Given this list of marker genes EPM2A, CEP57L1, AEBP2, DGKH, ERO1B, ZNF107, SOX17, DESI2, DPY19L4, CD99, C1orf43, ADCY3, KLHL11 (kelch like family member 11), LIMS3, KRBOX4, HSPA12A, RIMKLB (ribosomal modification protein rimK like family member B), KNOP1, RASSF8, PWWP2A, AKAP1, MAP7D2, LRRC19, ZIC3, SEMA3E, PTPRU, RAD51AP1, PUM2 (pumilio RNA binding family member 2), HHIP, CLVS2, TBL1XR1, C1QTNF7, TPP2, COX11, KRTAP4-3, APOBEC4, EML1, LIMS4, DIMT1 (DIM1 rRNA methyltransferase and ribosome maturation factor), GRIN2A, RPL7L1, PIH1D2, PLSCR1, RAPGEF2, COX16, RETREG1, CABS1, PARVA, F2R, SSPN, MCTP2, GALNT13, CD69, MLX, ZDHHC15, UBE2L3, HERC4, PTBP2, PSENEN, SYNJ2BP-COX16, DIS3, IDI1, MAPK10, CCDC25, ATRX, OSER1, GDA, DHX33, MYEF2, TRDMT1, ZFR, ALG13, AOC3, CDYL2, EBF3, ULK2, SLFN12, STAU2, RAB6D, ZBTB20, TFRC, TBL1X, FAM227B, NTS, ENPEP, AASDH, ACO1, C6orf89, TMEM255A, SLC4A10, PIK3C3, LARGE1, ZSCAN20, SGCB, WDR89, VPS13C, MED30, GTDC1, TMSB15B, FANCF, DRP2, ARL5B, LCORL, CD46, IFT80, FCHSD2, ZNF678, PGGT1B, FAM199X, ILRUN, EDIL3, RAB3C, CLEC7A, TMSB15A, PKD2, ID4, PPFIA2, SYT10, SFPQ, here is a description of the gene set: Genes predicted to be targets of miRBase v22 microRNA hsa-miR-4699-5p in miRDB v6.0 with MirTarget v4 prediction scores > 80 (high confidence targets). species: Homo sapiens Human Gene Set: MIR4699_5P from publication Chen Y, Wang X (PMID 31504780)